The following is a description of a gene set: studied in species Homo sapiens Human Gene Set: HP_LIMB_PAIN Chronic pain in the limbs with no clear focal etiology. Limb pain, and this is the list of marker genes: FLI1, COL5A2, LMX1B, SCO2, KRT14, FN1, NAGLU, COL11A1, KRT17, PRKRA, CCND1, GJB2, MFN2, MME, MATN3, LEMD3, MMP13, SLCO2A1, ATL3, SPTLC1, IDUA, ATL1, ACP5, TRAPPC2, NLRP12, TGFB1, KRT5, COL5A1, B2M, HYAL1, HTRA1, COL1A1 (collagen type I alpha 1 chain), SEPTIN9, ALDH18A1, TREX1, SPG7, VHL, ERLIN1, TONSL, HEPHL1, KRT6B, COL9A2, KRT6A, MAFB, RASA1, COL2A1, KRT16, MT-ATP6, HMBS, COL9A1, COMP, CPOX, GJB6, SPTLC2, BSCL2, COL9A3, MT-TK